Given this list of marker genes TTL, TMEM177, MLPH, BYSL, NMNAT2, ZC3H18, CYP11A1, CHML, HAT1, MAPRE1, TIMM50, COQ3, SUPV3L1, GFM1, PLPP2, WDR12 (NCBI Gene Id 55759), MIS18BP1, TRIAP1, LSM4, GOLT1B, EPDR1, UMPS, MRTO4, POLR3K, DOT1L, DR1, UCHL5, ATP11C, TIGAR, SDF2L1, SLC52A2, THUMPD2, LIN28B, USP5, SAP30, ATP6V0E1, GCLM, TMEM19, GEMIN5, MSH2, HPRT1, ZNF511, FAM162A, ODC1, PSD4, HPS1, SNRPF, ATP13A3, CTTN, CSK, MRPL18, MLEC, DNTTIP2, PUM3, ETF1, SCO1, XIAP, NFKBIB, ELOC, DEF8, MRPL36, ENDOD1, ME1, PNO1, NOP14, PCMT1, PDCD2L, JPT1, HMGB1, CALR, DDX20, PGK1, CHN2, BID (BH3 interacting domain death agonist), ZNF100, VCAN, PTS, CCT8, MIS18A, HNRNPU, HOMER1, CD58, RIPK2, SLC25A20, CALM3, SCG2, FAM83D (family with sequence similarity 83 member D), OBI1, SLC1A2, LRRC58, SFPQ, EIF5B, PACRG, LPGAT1, TUBB6, UHRF1, YARS2, SLC25A10, ELOCP29, ALDOA, NOP2, NFIC, NDUFS6, SCGB1D1, QRSL1, TFAM, MRPL42, CHCHD1, GOSR2, TFRC, MBP, EVI5L, LSM6 (NCBI Gene Id 730962), UNKL, UCHL3, INTS10, PSMD2, ARL5A, CCT2, ZNF330, GTF3C4, PPID (peptidylprolyl isomerase D), SFXN4, CALM2, LLPH, ANAPC5, APMAP, CEP15, MPZL1, PCDHB1, STEAP1, ESF1, NUDT19, TMEM38B, NME1-NME2, NUP88, DNTT, CANT1, TRMT6, EIF3B, SBNO1, LRP8, ATP5MC1, SRFBP1, MRPS18C, FAM216A, MRPL19, SEH1L, HAUS2, UTP4, PVR, DDIAS, GFOD1, XPO6, DCSTAMP, MRPS2, SRXN1, PRPS1 (NCBI Gene Id 8254), GLS (glutaminase), XRCC4, GTPBP3, CMC2, TRAFD1, CUTC, UBQLN1, CFL2 (NCBI Gene Id 1073), SLC25A32, SNRPD1 (NCBI Gene Id 6632), CARNMT1, PARP1, ANP32E, PSME3, PUS1, TMEM126B, INO80C, THAP5, PHF5A, CALM1, SURF4, CDC7, CEP78, C1orf115, COPS3, RABGGTB, GPAT3, KLHL8, DYNLT3, HNRNPDL, LEPROTL1, MYLK, EGLN1, POPDC3, ZNF267, SCARB1, LSG1, DNMT1, PNP, MRPS23, BUB1B (BUB1 mitotic checkpoint serine/threonine kinase B), MOG, TIPIN, C4orf46, PTDSS1, NUP37 (NCBI Gene Id 79023), MED10, GLRX3, SSX2IP, SH3GL2, ALDH1A3, HMMR, C15orf61, TEAD4 (NCBI Gene Id 7004), ORC6, SDC3, PLLP, CACYBP, TRIP13, CELA3A, CLN5, L3HYPDH (NCBI Gene Id 112849), MAPKAPK3, F2RL1, MCUR1, CTPS1 (CTP synthase 1), NDUFAF5, MRPS35, C2orf76, HELLS, MLKL, NAA25, TMEM138, MOB4, EIF2S1, HSPA1B, DUSP14, ATP6V1C1, PPM1G, SMARCA4, PGM2, MAD2L1, WDR4, OXNAD1, P2RX2, SAMD4A, PHLDA2 (pleckstrin homology like domain family A member 2), NR4A1, ATL3, TRIB1, PAICS, CHAC2, ASB9, SMC2, ZNF593, NSUN2, LDLRAD3, TXNDC9, ZBTB2, SLC18A3, CLN6, CEACAM6, PUS7, NXT2, BIRC5, PKNOX1, G3BP1, JKAMP, BPNT2, STARD3NL, DNAJB11, UQCC3, CHCHD4, AIRIM, CA12, CFAP410, IFT25, CA2, SLC16A1, LPCAT1, EXOSC2, ITGA6, CCDC137, NUP35, FOSL2, ABRACL, FAHD1, GEMIN6, UBE2N, TOR3A, UTP25, C4orf46P1, LYAR, GHITM, GTPBP10, IPO11 (NCBI Gene Id 51194), GLIPR1, URB2 (URB2 ribosome biogenesis homolog), SLC35G2 (solute carrier family 35 member G2), EHD4, MND1, MRPL41, LRR1, ADPGK, MAP2K6, PRMT3, PA2G4, ELOA, EFHD2, SLC9A1, GLRX2, DHX37, SLC39A2, GGA2, NOX1, SLC20A1, KITLG, ATL2, MRPL47, STARD7, PPP1R1A, PNPO, MRPS30, PSMD14, SYCP1, ZHX2, SRSF7, IRAK1, PNPT1, HSPA4, HSPA14, AURKB, CIAO2A, OSTM1, NFATC1, GGCT, CBFB, CASP8, ERGIC2, TPRKB, SELENOTP1, TIMM17A, SCFD2 (sec1 family domain containing 2), LAPTM4B, FBXO45, NUP43, OTUD6B, EFNA3, MCM4 (NCBI Gene Id 780917), SGO2, C9orf78, PDCD6, DBI, MYO5A, MRPL14 (mitochondrial ribosomal protein L14), GRB2, GNL2, HYAL2, MRPL58, NMT1, PABPN1, ATP2B1 (ATPase plasma membrane Ca2+ transporting 1), CDC123, ATP10B, YWHAH, TOX4, PPIH, PGP, CFAP20, WDR75, COMMD8, RAD51C, B3GALT1, NXPH4, CLN3, MAP2K3, BLOC1S6, CHRNA5, DIAPH1 (NCBI Gene Id 1729), KPNA6, ARNT, GLP1R, CCDC138, ZNF680, SYNCRIP, EEF1E1, HSPA8, N4BP2L1, MCMBP, RUVBL1, LACTB2, GRPEL1, DEPDC1B, RCL1, OAS2, HRAS, CCDC59, MRPL50, DCAF13, WDR77, LAS1L, SLC18A2 (solute carrier family 18 member A2), RFC3, HAUS6, OPA1, RIOK1, DSCC1 (NCBI Gene Id 79075), STIP1, FKBP4, NLN, CKAP4, KLHL13, DDX25, ZNRD2, APTX, PSMG1, CCND2, SF3B5, S100A2, RIPPLY3, PRIM2, C1orf131, FASN (NCBI Gene Id 2194), SPCS3, RLIG1, S1PR4, FAM210A, UTP18, MPHOSPH10, NAA15, TOMM5, BAG2, AHCTF1, SLC39A6, GRB10, HDHD5, SLC35B1, P2RX7, GMNN, NUP107, HPGD, UPF2, MRPL30, THOP1, NIFK, ASXL1, CHEK1, MTCH2, SAAL1, RBBP7, CDC6, GEM, LARP4, PBDC1, LLPHP3, ATP6V0B, NME2, MGST1, SULT2A1, BCAN (NCBI Gene Id 84774), MRPS28, NAE1, AKAP7, CDK1 (NCBI Gene Id 983), IDI1, NETO2, BCCIP, BASP1, NSDHL, SLIRP, RPS19BP1 (NCBI Gene Id 91582), TNPO3, PPRC1, PTPN7, MRPS12, TUBB, SLC39A8, GPN3, ZMYND19, FNDC4, DDX10, ARPC5L, GPR21, ANXA2, TIMM10, EIF2B3, GEN1, SHMT1, MSX1, SUCLG1, GOLM1, RFT1, ACLY, NOL11, TAF1A, CREM, CISD2, BMX, ACVR1B (NCBI Gene Id 93351), MAP7D1, POLE2, ISOC1, DCTPP1, AASDHPPT, RRP9, NUDCD1, MPHOSPH6, E2F3, POP7, LYSMD2, PWP1, NAMPT, RRP1B, GLI4, B4GALT2 (NCBI Gene Id 8704), SLC25A39, MRPL15, SELENOT, TAF9, RABEPK, DAZAP1, CHST4, OGFOD1, HGS, TAF4B, PPFIA4, POLE3 (DNA polymerase epsilon 3, accessory subunit), ANLN, MAN1A2, TMEM97, ENO1, DUS3L, BACE2, FIRRM, NUDT15, SKA3, DHX9, JADE2, IDE, CLEC4M, KTN1, RC3H1, MTFR2, ANKRD39, TRMT1, EIF5, ASAP3, TMEM70, AHRR, CCT7, BLM, PRR15L, RIF1, HLCS, C11orf24, QSER1, TAF13, ENOPH1, SLC39A14, CDCA5, MRPL1, HS2ST1, NOP16, TMEM167AP2, DPYSL3, AFG2B, KGD4, TJP2, RRP15, CNOT7, VDR, PPAT, MZT1, ZNF468, SKP2, BAZ1A, HSPA1A, POLR1B, DEPDC1, WNT2B, SVIP, TYRP1, DYNC1LI1, ASCC3, CWF19L1, MCM8, TRMT10C, PLCB1, ICAM2, MALSU1, SMC6, MTFR1, IMP4, POLE4, SRP19, ZMPSTE24, SDC1, HACD3, CORO7, DAPK3, LYN, ZNF639, TOP1, ALK, UCK2, ABCE1, KAT14, UXS1, DOLK, CCT6A (NCBI Gene Id 908), SPOCD1, EBP, NUP155, ZBTB38, RRM2 (NCBI Gene Id 6241), ABCC4, POLR1G, TTC27, NDUFV3, KANSL2, RFWD3, CCDC77, UAP1, PGBD5, EIF4G1, OAT, NDC1, STAMBPL1, POLR3B, MRPL22, HSPH1, SIVA1, POLR2F, PAPOLA, SSR1, KLHL18, EMP1, PRPF40A, ERO1A, MCM10, MRPL35, REXO2 (RNA exonuclease 2), SPRING1, CDC42, MTDH, FGA, BRIX1, MIX23, MYCN, UBE3B, SLC12A2, MRPL4, CERS6, NDUFAF4, DYNLL2, TMX1, TMED5, PRMT1, TOMM34, CENPV, FBXO22, CSRP2, NDUFAF6, AMD1, CMSS1, SPDL1, DCBLD2, DDX46, POP4, SNRNP70, RB1, MASTL, PMM2, KPNA4, SRPRB, CCNE2, PSMA3, PSMA5, FANCC, BCL3, FASTKD2, NOLC1, PPM1E, NUDT5, CYP3A4, PHB1, WDR1, NCS1, NUP58, RPP40, AHSA1, COPS8, GNPDA1, SMC1A, MESD, MTFMT, ATP23, CENPK, HNRNPM, RNF126, SMNDC1, KATNIP, TPM3, RNF138, NOP58, MANEA, HNRNPC, C9orf40, PALM2AKAP2, TSN, ATAD2, SERBP1, DUSP5, MIPEP, USP14, POP1, CISD1, KPNB1, DKC1, HTR3A, LONRF2, PSMD13, SERPINE2, CMC1, YDJC, DIMT1, ZFP41, LRFN4, TMEM167A, ZWILCH, E2F7 (NCBI Gene Id 144455), FLAD1, FGB, HAMP, NEDD4, ABCF2, MRPL27, RCC1, CCNE1, DDX21 (DExD-box helicase 21), CDC25A, CAPN15 (NCBI Gene Id 6650), RNASEH1, MRPL39, JADE3, UBAP2L, RAD54B, NDUFB3, SRPK1, ATP2A2, KANK1, RPP30 (NCBI Gene Id 283012), VMA21, DHX33, TIMM21, CRLS1, VRK1, LSM10, GNAO1 (G protein subunit alpha o1), DDX18, ZC3H13, GPD2, EXOSC3, WDR43, CENPA, SLCO4A1, C5AR2, CSE1L, VCP, METTL21A, G2E3, SIGMAR1, MRPS15, PSMD12, FARSB, PSMD1, SELENOI, MANF, TM2D2, LRRC15, HK2, SPHK1, SYMPK, ICAM3, HDAC8, RIOK2, EXOSC9, SRM, BUB1, AKAP1, PPIF, KCNMA1, CEACAM3, CCHCR1, here is a description of the gene set: Loss of 1p36 heterozygosity commonly occurs with MYCN amplification in neuroblastoma tumors, and both are associated with an aggressive phenotype. Database searches identified five microRNAs that map to the commonly deleted region of 1p36 and we hypothesized that the loss of one or more of these microRNAs contributes to the malignant phenotype of MYCN-amplified tumors. By bioinformatic analysis, we identified that three out of the five microRNAs target MYCN and of these miR-34a caused the most significant suppression of cell growth through increased apoptosis and decreased DNA synthesis in neuroblastoma cell lines with MYCN amplification. Quantitative RT-PCR showed that neuroblastoma tumors with 1p36 loss expressed lower level of miR-34a than those with normal copies of 1p36. Furthermore, we demonstrated that MYCN is a direct target of miR-34a. Finally, using a series of mRNA expression profiling experiments, we identified other potential direct targets of miR-34a, and pathway analysis demonstrated that miR-34a suppresses cell-cycle genes and induces several neural-related genes. This study demonstrates one important regulatory role of miR-34a in cell growth and MYCN suppression in neuroblastoma. Genes whose promoters contain E-box motifs and whose expression changed in MYCN-3 cells (neuroblastoma) upon induction of MYCN. from publication Wei JS, Song YK, Durinck S, Chen QR, Cheuk AT, Tsang P, Zhang Q, Thiele CJ, Slack A, Shohet J, Khan J (PMID 18504438) studied in species Homo sapiens Human Gene Set: WEI_MYCN_TARGETS_WITH_E_BOX